The following is a description of a gene set: Mouse Gene Set: GOBP_NEGATIVE_REGULATION_OF_NON_CANONICAL_WNT_SIGNALING_PATHWAY Any process that stops, prevents, or reduces the frequency, rate or extent of non-canonical Wnt signaling pathway. studied in species Mus musculus, and this is the list of marker genes: Ift80, Rnf213, Sfrp5, Lrp6, Znrf3, Mir154, Sfrp4